The following is a description of a gene set: Human Gene Set: MIR1261 from publication Chen Y, Wang X (PMID 31504780) Genes predicted to be targets of miRBase v22 microRNA hsa-miR-1261 in miRDB v6.0 with MirTarget v4 prediction scores > 80 (high confidence targets). studied in species Homo sapiens, and this is the list of marker genes: IRF2BP2, EIF2A, LATS2, UNC5B, BTBD9, CCR1 (NCBI Gene Id 1230), LAMTOR3, ZNF781, KPNA3 (NCBI Gene Id 3839), DAPK1, ATP2B2 (NCBI Gene Id 491), GSG1L, C8orf34, ST13, GAS2, WNK3, MIPOL1, SETD2, BMERB1, NAIP, MBNL3, MARF1, TMEFF1, KIF26B, NRIP1, HDAC3, CNTN4 (contactin 4), KPNA4, NR3C1, LRRTM3, ADGRL4, RBL1, SERPINA7, SLC16A14, SLC2A12, ARHGAP5, CCDC170, SOCS6, CTAGE1, AFF4, MAML2, TMEM47, SEPTIN3, PIP4P2, WDR44, SEPHS1, ZCCHC4, SACM1L, NARS1, PRDM5, RNF111, ARID2, RNF43, GABARAPL2, CCDC82, OSBPL1A, ITGAL, MSANTD3-TMEFF1, OSBPL6, CPXM2, ADAM30, USP1 (ubiquitin specific peptidase 1), NRXN1, CDH6, ANGPTL3, METAP2, CCDC68, FAM171A1, PWWP2A, KCNK12, PROSER1, ANAPC11, NHLH2, ZNF382, CDH7, PRSS12, ZCWPW2, ATF3, NFE2L1, PTHLH, ZIC2, GTPBP4, AGK, ZNF585B, KIF3A, UBE2L3, INSIG1